Given this list of marker genes TSPAN6, CNOT6, SEC24D, ALG6 (NCBI Gene Id 94752), TMEM161A, AMZ2, ECH1, UQCRFS1, MRPS24, FAM171B, MTHFSD, ZBED4, APPL2, RTN3, AGR3, VPS36, RAD17, LBR, SCAMP1, TM2D2, CAMLG, BCL2L1, SAYSD1, GASK1B, EGFL7, PPP6C, TOB1 (NCBI Gene Id 10140), PDCL, CCDC32, PSMD10, NDUFA4, ZFP36L1, PDGFA, M6PR, IFNA13, SPG11, HERC4, ZRANB2, VAMP5, CACNG4, TSPAN7, BDP1, IFT122, ZBED5, RPA3, WDR19, CHAMP1, SUB1, APOD, CRLS1, FCGRT, HSD17B11, STRN3, ZKSCAN4, PCNA, ATP2A3, MTPN, TGM3, CCP110, TM7SF3, GPR37, SCAND1, ATP5IF1, DCUN1D1, GATD3, JRKL, ITGB3BP, PIGP, ADGRV1, ACBD3, LIPA, PGS1, HAGH, HIGD2A, TM4SF4, PJA2, DDIT4, RTL8A, PRDX1, SLC11A2, PLTP, here is a description of the gene set: Genes in the cancer module 243. Human Gene Set: MODULE_243 studied in species Homo sapiens